Given this list of marker genes Cpeb1, Adcyap1r1, Abr, Kcna6, Fbxl9, Nuf2, Col27a1, Phf8, Mob3a, Scgb3a1 (secretoglobin, family 3A, member 1), Tln1 (NCBI Gene Id 21894), Gpr3, Nfasc, Sorbs3, Macrod1, Arid1a, Epb41l1, Cyp2c40, Cyp2c67, Ptrh2, Gga3, Dpysl3, Hsf2, Sh3gl1, Pcdh7, Pla2g4b, Bgn, Vmn1r65, Erlin1 (NCBI Gene Id 98152), Nol12, Nav1, Cdc37l1, Naa50, Igf2bp3, Nipsnap2, Vti1a, Tbl1xr1, Ncoa1, Csf1r, Dgkk, Prpf4, Parp14, Sfrp2, Fam217a, Serpinb8, Slc15a1, Erfe, Ppp5c, Atcay (ataxia, cerebellar, Cayman type), Sema3g, Nfic, Syt6, Ulk1, Dlg2, Ift52, Cbfa2t3 (NCBI Gene Id 320906), Ldlrap1, Loxl2, Med26, Stx16, Pdxp, Nr2c2, Slc9a4, Sirpa, 5730455P16Rik, Nfatc4 (nuclear factor of activated T cells, cytoplasmic, calcineurin dependent 4), Golga1, Padi1, Mrpl35, Rfng, Galnt6, Szrd1, Rab11b, Siae, Scn4b, Itpripl2, Caln1, here is a description of the gene set: from publication Chen Y, Wang X (PMID 31504780) Mouse Gene Set: MIR_7669_3P studied in species Mus musculus Genes predicted to be targets of miRBase v22 microRNA mmu_miR_7669_3p in miRDB v6.0 with MirTarget v4 prediction scores > 80 (high confidence targets).